The following is a description of a gene set: Reactome Pathway: MITF-M-dependent gene expression species: Homo sapiens MITF-M is a transcriptional regulator that is critical for the establishment of melanocyte fate during embryogenesis. Key targets include the enzymes responsible for the synthesis of the pigment compounds eumelanin and pheomelanin, as well as a number of structural components of the melanosome. In addition to regulating expression of genes involved in pigmentation, MITF has also been shown to play a role in the expression of genes involved in more diverse biological processes, including proliferation, survival, lysosome biogenesis, autophagy, metabolism, DNA damage, senescence and invasion. Although widely characterized as a transcriptional activator, MITF-M has also be shown to act as a transcriptional repressor, negatively regulating the expression of genes involved in extracellular matrix organization, focal adhesion and epithelial-to-mesenchymal transition.<br>MITF is a basic helix loop helix leucine zipper (BHLH-ZIP)-containing protein and binds DNA as a dimer - either as a homodimer or as a heterodimer with the related transcription factors TFEB, TFE3, and TFEC. TFEB and TFE3 are both widely expressed, but TFEC displays more restricted expression. In this pathway, for simplicity, MITF is shown binding DNA exclusively as a homodimer. <br>MITF and related BHLH protein family members bind to an E-box-like element with sequence CANNTG. Specificity of binding is determined both by the flanking nucleotides and by the identity of the two internal nucleotides of the E-box element. MITF binds preferentially to sequences CATGTG or CACGTG, and binds with less affinity to the CAGCTG sequences preferred by other BHLH proteins such as AP4. High-affinity MITF-binding sites also show an enrichment for flanking 5'T and 3'A, further distinguishing these sites from those preferentially bound by transcription factors such as MYC and MAX. Variants of high-affinity MITF binding sites present in the promoters of pigmentation genes are called M-boxes, to distinguish them from related E-box sequences. Direct targets of MITF-M have been identified by ChIP-seq and CUT-and-RUN analysis in a number of primary and melanoma cell lines. In one of these studies, high-throughput ChIP-seq in the human melanoma cell line 501Mel identified MITF-binding at 5578 potential target genes, with 2771 showing promoter-proximal binding; only a subset of these genes were shown to be directly regulated by MITF, however (465; 240 down-regulated upon MITF knockdown, and 225 upregulated upon MITF overexpression). MITF-bound genes included those involved in melanocyte biogenesis as well as DNA replication, repair and mitosis. Other studies have identified roles for MITF-M as a direct repressor of a number of genes implicated in estracellular matrix organization, cell adhesion, invasion and epithelial-to-mesenchymal transition. part of: MITF-M-regulated melanocyte development, and this is the list of marker genes: SMARCE1, ATP6V0A1, SMARCC2, ACTB, STT3B, ATP6V1B2 (NCBI Gene Id 526), TNRC6C, ATP6V0C, LEF1, TFAP2A, TCF7L2, BCL2A1, LIG1, TCF7L1, BCL7C, MITF, CTNNB1, SS18, MYRIP, ZEB1, ATP6V1E1, CDC25B, ATP6V0B, ATP6V1F, ATP6V1C1, PXDN, POU3F2, MET, CDKN2A, HDAC1, DPF3, DPF1 (double PHD fingers 1), TYRP1, SMARCC1, ATP6V0E1, SMARCA2, ATP6V1A, TBX2, ATP6AP2, TRPM1, CCND1, ASAH1, ATP6V1G1, MCM5, SOX2, IRF4, AGO2, SIN3A, CREB1, MCM2, DIAPH1, SERPINE1, TNRC6A, BRCA1, MAPK14, TCF7, SMARCD1, PXN, AKT2, AGO1, AGO4, BCL7B, ATP6V1D (NCBI Gene Id 51382), ACTL6A, CCNB1 (cyclin B1), CEACAM1, SMARCB1, TYR, DPF2, EDIL3, ARID1B, GPR143, DICER1, GXYLT2, MLPH, MYO5A, PLK1, MOV10, SS18L1, CDH1, TNRC6B, BCL7A, GMPR, CDK2, RAB27A (NCBI Gene Id 5873), ATP6V0D1, SMARCD2, SMARCD3, CDKN1A, BIRC7, ITGA2, USF1, ATP6V0E2, ARID1A, SOX10, MIR211, PPARGC1A, DCT, CDH2, SYTL2, SIRT1, AGO3, HINT1, ATP6V1H, TERT, SMARCA4, PMEL, BCL2, MLANA